Given this list of marker genes Meg3, Rpl35, Rpl34, Mgll, Rbm39, Ubb-ps, Chchd7, Ndufc1, Eif5, Rpl18, Ecrg4, Rpl32, Cnn2, Rpl13, Fmc1, Cltb, Rps24, Atp5if1, Ndufb2, Ankrd29, Rpl14, Cyba, Rps7, Spcs1, Emp3, Ndufv3, Pfdn1, Sertad1, Fam162a, Gm6981, Rhoc, Snrpc, Rpl31, Fkbp3, Rps20, Micos13, Ndufb7, Pold4, Rps26, Atp5mg, Ppp1r11, Gng5, Cox5a, Tmem11, Tmsb10, Ranbp1, Lyz2, Rps27l, Selenom, Nbl1, Ccl7, Btf3, Map1lc3a, Atp6v0c, Rpl18a, Rps27, Serf2, Selplg, Eif3k, Rpl6 (NCBI Gene Id 19988), Atp5mc1, Rpl27a, Rplp2, Ifitm3, Ndufc2, Vcf1, Cycs, Eif3g, Nop10, Rpl9, Fth1, Ndufb11, Ndufa13, Crip1, Cfl1, Arpc3, Car3, Rps27a, Cavin3, Manf, Jsrp1, Rabac1, Slc2a5 (NCBI Gene Id 56485), Cenpx, U2af1, Rhoh, Uqcr10, Anxa3 (annexin A3), Prelid1, Rplp0, Micos10, Krt14, Drap1, Cox6c, Srrm2, Swi5, Mir24-2, Gas5, Eny2, Sh3bgrl3, Rplp1, Gpx4, Gstp1, Cox6a1, Rpl22, Mrpl23, Ftl1 (ferritin light polypeptide 1), Ntmt1, Atp5mc2, Naca, Myl6, Oaz1, Clic4, Dynlrb1, Rarres2, Mt1, Hmgb1, Calm1, Cst3, Atp5f1d, Cryab, Rps15a, Nppc (NCBI Gene Id 18159), Pfdn5, Sde2, Tnfrsf12a, Rps14, Cxcl1, Ndufb6, Gstm1, Tpt1, Atp5pf (ATP synthase peripheral stalk subunit F6), Rpl11, Rpl21, Ccdc59, Mif, Tle5, Rps10, Nhp2, Pdcd5, Apoe, Zmat5, Psmb2, Rps9, Ppp1r14b, Rpl22l1, Uqcrq, Fxyd1, Ncl, Gadd45b, Edf1, Ptma, Nfkbia, Fkbp2, Rps15, Bcl7c, Anapc11, Psmb4, Cox4i1, Selenow, Rpl36al, Tnnt1, Elob, Pfn1, Hint1, Hspe1, Tmsb4x, Atox1, Rnaset2b, Mt2, Tomm6, Mrpl52, Snrpd2, Eif1ax, Hsp90aa1, Arl3, Rbis, Rpl41, Psmb6, Pfdn6, Tcf7l2, Rpl34-ps1, Rpl17, Ndufa12, Gpx3, Rps5, Sarnp, Tpm2, Cox8a, Pdap1, Snrpg, Smdt1, Eno1b, Romo1, Ccl2, B2m, Rpl28, Rps13, Rbm8a, Bola1, Atp5mc3, Sub1, Ifitm2, Hypk, Nedd8, Rps11, Rpl24, Uqcc2, Id3, Ccdc85b, Lsm4, Rps18, Gal, Trir, Dad1, Flnc, Rpl13a (ribosomal protein L13A), H2az2 (H2A.Z histone variant 2), Dcn, Tuba4a, Rpl26, Son (NCBI Gene Id 98027), Rpl27, Atp5mf, Capg, Adh1, Psmb9, Rps8, Capzb, Park7, Nme2, Fau, Gadd45a, Cd63, Mrpl17, Snrpd3, Bloc1s1, Tppp3, Pfdn2, Dynll1, Ndufa7, Cox6b1, Tmem160, Rpl36, Ccdc124, Chmp2a, here is a description of the gene set: from publication Tabula Muris Consortium (PMID 32669714) species: Mus musculus Mouse Gene Set: TABULA_MURIS_SENIS_DIAPHRAGM_SKELETAL_MUSCLE_SATELLITE_CELL_AGEING